The following is a description of a gene set: Female steroid hormones in cardiomyocyte energy metabolism species: Homo sapiens Human Gene Set: WP_FEMALE_STEROID_HORMONES_IN_CARDIOMYOCYTE_ENERGY_METABOLISM, and this is the list of marker genes: MTTP, ACADM, APOB, MAPK1, PPARA, AKT2, PPARGC1B, ESRRA, ACLY, STK11, HADHB, ESR1, SLC2A4 (solute carrier family 2 member 4), NOS3